The following is a description of a gene set: Human Gene Set: GOMF_ANKYRIN_BINDING studied in species Homo sapiens Binding to ankyrin, a 200 kDa cytoskeletal protein that attaches other cytoskeletal proteins to integral membrane proteins., and this is the list of marker genes: KCTD6, NRCAM, PTPRC, FLNC, SLC8A1, RHBG, SPTBN4, RHCG, PLEC, SPTBN1, SPTB, KCNQ2, CDH1, KCNJ11, RHAG, SLC4A1, OBSCN, SCN5A, CACNA1D